Given this list of marker genes EIF4A2, PCBP1, SEC61B, BEX3, RBM39 (NCBI Gene Id 9584), RPL38, EEF2, NACA2, RPL7, TSC22D1, ATP5MJ, COX6C, GABARAP, RPL34, ACTG1, ATP5PB, ATP5PO, DDX5 (NCBI Gene Id 1655), HNRNPDL, FAU, SRP14, EEF1G, SKP1, NDUFA13, SUB1, H3-3B, SF3B1, ATF4, RPL3, RSRC2 (arginine and serine rich coiled-coil 2), HNRNPU, RPL28, HNRNPA2B1, COX6B1, RPS8, RPL13, ELOB, SERBP1, PSMB4, SRSF5, ACTB, FMC1-LUC7L2, RPS4X, RPL15, ATP5F1E, RBM8A, SON, SUMO2, UBB, ATP5F1B, RPL31, SEC61G, CFL1, CHCHD2, ATP5ME, BZW1, COX4I1, HNRNPK, HSPA8, RPL6, RPL7A, UBL5 (ubiquitin like 5), ATP5MG, BRK1, TUBA1B, UQCRB, SLC25A3 (NCBI Gene Id 5250), RPL41, RPL8, SAP18, MARCKS, EEF1A1, RPL9, PFDN5, RPL14, RPS27A, DYNLL1, PARK7, UQCRQ, here is a description of the gene set: Human Gene Set: MANNO_MIDBRAIN_NEUROTYPES_BASAL Cell types are named using anatomical and functional mnemonics prefixed by 'm' or'h' to indicate mouse and human respectively: OMTN, oculomotor and trochlear nucleus; Sert, serotonergic; NbM, medial neuroblast; NbDA, neuroblast dopaminergic; DA0-2, dopaminergic neurons; RN, red nucleus; Gaba1-2, GABAergic neurons; mNbL1-2, lateral neuroblasts; NbML1-5, mediolateral neuroblasts; NProg, neuronal progenitor; Prog, progenitor medial floorplate (FPM), lateral floorplate (FPL), midline (M), basal plate (BP); Rgl1-3, radial glia-like cells; Mgl, microglia; Endo, endothelial cells; Peric, pericytes; Epend, ependymal; OPC, oligodendrocyte precursor cells. from publication La Manno G, Gyllborg D, Codeluppi S, Nishimura K, Salto C, Zeisel A, Borm LE, Stott SRW, Toledo EM, Villaescusa JC, Lönnerberg P, Ryge J, Barker RA, Arenas E, Linnarsson S (PMID 27716510) species: Homo sapiens